The following is a description of a gene set: Human Gene Set: GOBP_RNA_3_END_PROCESSING studied in species Homo sapiens Any process involved in forming the mature 3' end of an RNA molecule., and this is the list of marker genes: PAF1, FBL, CPSF7, REXO1L1P, PAPOLA, MBLAC1, TRNT1, CDC73, INTS9, INTS14, PTCD1, ERI1, CPSF3, RPRD2, INTS6L, INTS1, ELAC2, RPS21, EXOSC3, TENT2, CDK9, EXOSC7, RPRD1B, ZC3H3, SSU72, CPSF2, EXOSC5, LEO1, EXOSC9, EXOSC10, NCBP2, INTS8, NCBP1, TENT4A, REXO5, LARP7, CLP1, AHCYL1, SSB, SUPV3L1, INTS12, INTS6, SAGE1, SAGE2P, ANGEL2, CPEB1, CSTF3, TOE1, WDR33, HSD17B10, USB1, LIN28A, INTS11, EXOSC6, TUT4, DKC1, TUT1, EXOSC8, NUDT21, INTS2, EXOSC4, YTHDC1, TRMT10C, PARN, CPSF6, CSTF1, CSTF2T, INTS7, PAPOLB, PAPOLG, SLBP, INTS5, LSM10, CSTF2, ELAC1, FBLL1, MTPAP, PNLDC1, REXO1, CPSF1, PCF11, DHX36, LIN28B, RPRD1A (NCBI Gene Id 55197), EXOSC2, ZCCHC8, PNPT1, ZNF473, CCNB1, LSM11, ZFP36L1, TUT7, BARD1, TENT4B